The following is a description of a gene set: The chemical reactions and pathways resulting in the breakdown of amino acids of the serine family, comprising cysteine, glycine, homoserine, selenocysteine and serine. Mouse Gene Set: GOBP_SERINE_FAMILY_AMINO_ACID_CATABOLIC_PROCESS studied in species Mus musculus, and this is the list of marker genes: Scly, Cbs, Sds, Gldc, Thnsl2, Agxt, Gcsh (NCBI Gene Id 68413), Shmt1, Amt, Cdo1, Sdsl, Csad